The following is a description of a gene set: studied in species Homo sapiens A reduced level of insulin-like growth factor 1 (IGF1) in the blood circulation. Decreased serum insulin-like growth factor 1 Human Gene Set: HP_DECREASED_SERUM_INSULIN_LIKE_GROWTH_FACTOR_1, and this is the list of marker genes: RBM28, STAT5B, GHRHR, NFKB2, SMPD1, SIK3, GALT, IGF1, GHR, GH1, ALG12, PGM1, CTSK, SOX3, ADAT3, IGFALS, GHSR, DCAF17, KIAA0753, DNA2, MED12, ROBO1, MCTP2, MPDU1